The following is a description of a gene set: Mouse Gene Set: GOBP_RESPONSE_TO_MOLECULE_OF_FUNGAL_ORIGIN Any process that results in a change in state or activity of an organism (in terms of movement, secretion, enzyme production, gene expression, etc.) as a result of a stimulus by molecules of fungal origin such as chito-octamer oligosaccharide. species: Mus musculus, and this is the list of marker genes: Tlr2, Syk, Scimp, Clec7a, Slc22a19, Btk, Myd88